Given this list of marker genes SUZ12, UBA52, RUNDC3A, CAMTA1, SPTY2D1, CXXC5, EML1, NDUFS1 (NADH:ubiquinone oxidoreductase core subunit S1), RNF2, NAMPT, ELAVL2, GABRB3, PIEZO1, BMPR1A, ERO1B, LTBP1, ACTR1B, BACH2, ORC5, SLC6A19, PDE4D, PSD3, MKX (NCBI Gene Id 283078), TCEAL9, PTK2B, TEX30, STC2, BAHCC1, ZFHX4, P4HA1, TRIM33, MEIS2, TMX3, BTG2, RAB4A (NCBI Gene Id 5867), SH3RF1, RNASE11, NUP205, PDCD7, GPC4, UGCG, CERT1, MAPK10, ERG, MFSD14B (major facilitator superfamily domain containing 14B, NCBI Gene Id 84641), GMEB1 (NCBI Gene Id 10691), TBC1D25, NFIA, CTBS, MRPS6, SLCO4C1, RALYL, SRP19, TLL1, OTX2, SLC6A14, COL25A1, CLDN1, GFRA1, CCND2, PITPNB, FURIN, GHR, ASCC3, ZNF700, CA4, RCOR1, TENT2, PDLIM2, HPGD, CCNG2, LRRN3, TOX, SLC35A3, ATP7B, MRPL50, UBE2N (NCBI Gene Id 7334), MARCKS, BAG2, GATA3, COG8, LPAR6, KCNJ13, SRSF3, BMPR2, here is a description of the gene set: Human Gene Set: MIR3912_5P from publication Chen Y, Wang X (PMID 31504780) Genes predicted to be targets of miRBase v22 microRNA hsa-miR-3912-5p in miRDB v6.0 with MirTarget v4 prediction scores > 80 (high confidence targets). studied in species Homo sapiens